Given this list of marker genes ID3, TGFB1, SERPINE1, SMAD6, ID1, ID2, ID4, SMAD7, here is a description of the gene set: species: Homo sapiens Deregulated activation of the Src tyrosine kinase and heightened Id1 expression are independent mediators of aggressive tumor biology. The present report implicates Src signaling as a critical regulator of Id1 gene expression. Microarray analyses showed that Id family genes were among the most highly down-regulated by incubation of A549 lung carcinoma cells with the small-molecule Src inhibitor AZD0530. Id1 transcript and protein levels were potently reduced in a dose-dependent manner concomitantly with the reduction of activated Src levels. These effects were conserved across a panel of lung, breast, prostate, and colon cancer cell lines and confirmed by the ability of PP2, Src siRNA, and Src-blocking peptides to suppress Id1 expression. PP2, AZD0530, and dominant-negative Src abrogated Id1 promoter activity, which was induced by constitutively active Src. The Src-responsive region of the Id1 promoter was mapped to a region 1,199 to 1,360 bps upstream of the translation start site and contained a Smad-binding element. Src was also required for bone morphogenetic protein-2 (BMP-2)-induced Id1 expression and promoter activity, was moderately activated by BMP-2, and complexed with Smad1/5. Conversely, Src inhibitors blocked Smad1/5 nuclear translocation and binding to the Src-responsive region of the Id1 promoter. Consistent with a role for Src and Id1 in cancer cell invasion, Src inhibitors and Id1 siRNA decreased cancer cell invasion, which was increased by Id1 overexpression. Taken together, these results reveal that Src positively interacts with the BMP-Smad-Id pathway and provide new ways for targeted inhibition of Id1. from publication Gautschi O, Tepper CG, Purnell PR, Izumiya Y, Evans CP, Green TP, Desprez PY, Lara PN, Gandara DR, Mack PC, Kung HJ (PMID 18381431) Genes down-regulated in A549 cells (lung cancer) after treatment with AZD0530, a SRC kinase inhibitor. Human Gene Set: GAUTSCHI_SRC_SIGNALING